The following is a description of a gene set: Mouse Gene Set: REACTOME_TOLL_LIKE_RECEPTOR_9_TLR9_CASCADE species: Mus musculus Toll Like Receptor 9 (TLR9) Cascade, and this is the list of marker genes: Cd14, Rela, Uba52rt, Rps6ka2, Ppp2ca, Mapk11, Traf2, N4bp1, Ripk2, Map2k7, Mapkapk2, Mapk1, Casp8, Ager, Ube2n, Cul1, Rps6ka1, Fbxw11, Tab3 (TGF-beta activated kinase 1/MAP3K7 binding protein 3), Map2k4, Nod2 (nucleotide-binding oligomerization domain containing 2), S100b, Tlr4 (NCBI Gene Id 21898), Irak1, Eea1, Peli3, Nkiras2, Tnip2, Ppp2r1b, Hmgb1, Map2k3, Dusp6, Ubb, Dusp3, Mapk8, Ly96, Map3k7, Jun, Uba52, Nfkbib, Pik3c3, Ikbkg, Slc15a4 (solute carrier family 15, member 4), Ppp2cb, Nlrx1, Mapk3 (mitogen-activated protein kinase 3), Ppp2r5d, Fos, Nfkb2, Tab1, Alpk1, Ubc, Creb1, Rbsn, Ube2v1, Nlrc5, Nfkbia, Nfkb1, Mapkapk3, Lrrc14, Irf7, Rps6ka3, Peli2, Nod1, Ikbkb, Peli1, Traf6, Tasl, Vrk3 (vaccinia related kinase 3), Ecsit, Nkiras1, Irf5, Dusp7, Dusp4, Mapk10, Mapk7, Map3k8, Usp14, Skp1, Atf2, Ticam2, Tifa, Irak2, Atf1, Usp18, Rps27a, App, Map2k6, Mapk14, Rps6ka5, Tab2, Ppp2r1a (protein phosphatase 2, regulatory subunit A, alpha), Chuk, Mapk9, Pik3r4, Ticam1, Tlr9